Given this list of marker genes LBR, XYLT2, TCIRG1 (NCBI Gene Id 8845), LEMD2, TAPT1, BICD2, TNFRSF11A, CLCN7, SQSTM1, TBCD, MTAP, TRPV6, here is a description of the gene set: A partial or complete breakage of a lone bone (e.g., the femur, tibia, fibula, humerus, radius, and ulna). Human Gene Set: HP_LONG_BONE_FRACTURE Long-bone fracture species: Homo sapiens